The following is a description of a gene set: Mouse Gene Set: REACTOME_SHC1_EVENTS_IN_EGFR_SIGNALING studied in species Mus musculus SHC1 events in EGFR signaling, and this is the list of marker genes: Btc, Hbegf, Tgfa, Hras, Kras, Grb2, Egfr, Egf, Shc1 (NCBI Gene Id 20416), Epgn, Ereg, Areg, Sos1